Given this list of marker genes RUFY1, ARHGEF9, RNF216, VANGL2, RAPGEFL1, MSL1, MAPK1, CACNB3, KRTAP10-7, PTAR1, EMILIN3, ERCC6L, MBD3, ARNT2, PEX16, BAHD1, TSPAN7, ACAP3 (ArfGAP with coiled-coil, ankyrin repeat and PH domains 3), NFAM1, MLXIP, C6orf89, PHF19, RING1, CNTNAP2, LSM12, JDP2, CAMK2G, SALL1, MGAT5 (NCBI Gene Id 4249), ZKSCAN2 (NCBI Gene Id 342357), CDC42, TRMT61A, BTN2A1, EFNB1, MARCHF3, MYOCD, CAMKV, KSR2, BTN2A2, ADAM11, LDLRAP1 (low density lipoprotein receptor adaptor protein 1), NUDT5, UBE2H, RIMS3, PRRT2, NPLOC4, ATG9A, CASP10, ESRRA, TMEM25, CAPNS1, FEM1C, ATP6V0A1, SNPH, UBE2V1 (NCBI Gene Id 7335), SYK, TNPO1, RORA, PLCXD3, N4BP3, JADE2, E2F7, CANX, RLN3, MAFG, DUSP26, EIF2AK1, CAVIN1, VPS39, TTYH3, MTCP1, MPZ, MTCL2, PLAG1, LAMTOR3, MVB12A, RC3H1, SSH3, RAB1B, HRH3, PIPOX, ADGRE2, PLEKHH3, ZNF704, PUM1, CNNM4, RASGEF1A, LRP3, STAG1, ZMAT3, LARGE1, ADCYAP1R1, ZCCHC24, RAB23, GRM7, TTYH2, RIC3, SLC2A13, TGIF2, CGREF1, STOML1, CEMIP, DOCK9, SHC3, XPO7, ZDHHC22, PLXNA2, STEAP3 (NCBI Gene Id 55240), SRP68, TEX19, TPRA1, PCYT2, NFIX, MEF2D, FGF1, ADAMTS10 (ADAM metallopeptidase with thrombospondin type 1 motif 10), RAB4B, PABIR3, PAQR4, NR6A1, UBA7, IQSEC2, LHPP, CARMIL1, AMZ1, FOXN4, KIF21B, here is a description of the gene set: studied in species Homo sapiens Genes predicted to be targets of miRBase v22 microRNA hsa-miR-6836-5p in miRDB v6.0 with MirTarget v4 prediction scores > 80 (high confidence targets). from publication Chen Y, Wang X (PMID 31504780) Human Gene Set: MIR6836_5P